Given this list of marker genes GNG2 (NCBI Gene Id 54331), GNG4, GNG8, GNB3, GNG13, GNB5, GNB4, GNG3, GNG11, BTK, GNG10, GNB1, GNGT2, GNB2, GNGT1, GNG5, GNG12, GNG7, here is a description of the gene set: part of: G-protein beta:gamma signalling G-Protein Coupled Receptors (GPCR) sense extracellular signals and activate different Guanine nucleotide binding proteins (G-proteins) that have alpha, beta and gamma subunits. Upon activation, the alpha subunit of G-proteins dissociates from beta-gamma and the both are then free to regulate downstream effectors. G-protein beta-gamma complex, along with phosphatidylinositol 3,4,5-trisphosphate (PIP3), recruits the non-receptor Tyrosine-protein kinase BTK to the cell membrane. Here, the G-protein beta-gamma complex activates BTK. Subsequently, active BTK dissociates from the complex to phosphorylate downstream substrates. Physiologically, BTK plays a key role in B lymphocyte development, differentiation and signalling. Reactome Pathway: G beta:gamma signalling through BTK studied in species Homo sapiens